Given this list of marker genes Xdh, Cyp3a13, Cyp1a2, Cyp2c66, Vkorc1, Rrm1, Rrm2b, Cyp2c29, Cyp2c39 (NCBI Gene Id 13098), Cyp2c37, Rrm2, Cyp2c38, Acox2, Cyp2c65, Vkorc1l1, Cyp2c50 (cytochrome P450, family 2, subfamily c, polypeptide 50), here is a description of the gene set: Mouse Gene Set: GOMF_OXIDOREDUCTASE_ACTIVITY_ACTING_ON_CH_OR_CH2_GROUPS species: Mus musculus Catalysis of an oxidation-reduction (redox) reaction in which a CH2 group acts as a hydrogen or electron donor and reduces a hydrogen or electron acceptor.